The following is a description of a gene set: Human Gene Set: ZHAN_MULTIPLE_MYELOMA_CD1_VS_CD2_DN To better define the molecular basis of multiple myeloma (MM), we performed unsupervised hierarchic clustering of mRNA expression profiles in CD138-enriched plasma cells from 414 newly diagnosed patients who went on to receive high-dose therapy and tandem stem cell transplants. Seven disease subtypes were validated that were strongly influenced by known genetic lesions, such as c-MAF- and MAFB-, CCND1- and CCND3-, and MMSET-activating translocations and hyperdiploidy. Indicative of the deregulation of common pathways by gene orthologs, common gene signatures were observed in cases with c-MAF and MAFB activation and CCND1 and CCND3 activation, the latter consisting of 2 subgroups, one characterized by expression of the early B-cell markers CD20 and PAX5. A low incidence of focal bone disease distinguished one and increased expression of proliferation-associated genes of another novel subgroup. Comprising varying fractions of each of the other 6 subgroups, the proliferation subgroup dominated at relapse, suggesting that this signature is linked to disease progression. Proliferation and MMSET-spike groups were characterized by significant overexpression of genes mapping to chromosome 1q, and both exhibited a poor prognosis relative to the other groups. A subset of cases with a predominating myeloid gene expression signature, excluded from the profiling analyses, had more favorable baseline characteristics and superior prognosis to those lacking this signature. species: Homo sapiens from publication Zhan F, Huang Y, Colla S, Stewart JP, Hanamura I, Gupta S, Epstein J, Yaccoby S, Sawyer J, Burington B, Anaissie E, Hollmig K, Pineda-Roman M, Tricot G, van Rhee F, Walker R, Zangari M, Crowley J, Barlogie B, Shaughnessy JD Jr (PMID 16728703) Genes down-regulated in CD-1 compared to CD-2 cluster of multiple myeloma samples., and this is the list of marker genes: GPR160 (NCBI Gene Id 26996), SC5D, PRDM5, MGAT3, TBC1D1, CD27, RNGTT, KLHL14, CSNK1G3, STAP1, SEC62, TLK1, ENO2, LAMA5, CD1D, RAB3B, CXCR4, RASSF6, NME4, ST6GAL1, CPQ, NAV2, LAPTM4B, PLPP3, TNS3, PRKCB, OSBPL10, RAPGEF5, UBE2D2, SORT1, PRKCA, CORO1C, DUS2, PNOC, ZNF215, C2orf76, DENND5B, PIK3AP1, SINHCAF, NEK6, BLNK, LRRK2-DT, TMTC2, RGCC (regulator of cell cycle), SPINT2, SLFN11, TAFA5, SBF2, RYK, TNFRSF13C, BCL11A, GM2A, STXBP6